Given this list of marker genes NDP, TGFBR2, COL3A1, TGFB3, TGFBR1, TGFB2, SMAD3, IPO8, SMAD2, here is a description of the gene set: Uterine rupture Human Gene Set: HP_UTERINE_RUPTURE species: Homo sapiens